The following is a description of a gene set: species: Homo sapiens Genes predicted to be targets of miRBase v22 microRNA hsa-miR-4539 in miRDB v6.0 with MirTarget v4 prediction scores > 80 (high confidence targets). Human Gene Set: MIR4539 from publication Chen Y, Wang X (PMID 31504780), and this is the list of marker genes: EML4, EPB41L3, SNX11, MARCHF6, ERCC6L, CADM1, LRRC59, FHIP2A, MRPL47, KBTBD3, ITGAV, ATL3, KIF5B, COBLL1, RAD21, CLXN (NCBI Gene Id 79645), LPGAT1, B3GALT2, TOX4, IL33 (interleukin 33), ARL6IP6, EGR2, MAP3K2, ZNF251, PPM1E, HOXC4, LY9, ZHX3, NEIL2, ARGLU1, IDI1, CSNK2A1, PAK2, RIMS2, DPP10, TRDN, RAB28, ZNF367, ACBD3, EMC8, VWC2, ORMDL1, ANKRD34A, NIPAL1, ATP8A1, FAM199X, FRMD6, EPC2, PPIL4, AKTIP, MAGEE2, PEX13, SMYD2, ELOC, PTPN4, GRIA3, CNKSR2, VPS4B, COA5, PLEKHM3, TMEM33, ZBTB34, CIMIP2C, HNRNPDL, NXN, RTKN2, ZNF827, RFX4, SLFN13, TFAP2A, NIPA1, PTCH1, C21orf91, AZIN1, CCDC178, CCDC14 (coiled-coil domain containing 14), CIMAP2, RBM14-RBM4, ITPRIPL2, GTF2A1